The following is a description of a gene set: studied in species Homo sapiens We identified Pparg as a major orchestrator of the phenotype of adipose-tissue resident regulatory T cells (VAT Tregs). To establish the role of Pparg in shaping the VAT Tregs gene profile and cell dynamics, Tregs from lymph nodes and visceral adipose tissue of mice sufficient and deficient of Pparg expression in Tregs were double sorted for microarray analysis. Genes down-regulated in T conv from lymph node of elderly (retired breeder) mice: wildtype versus PPARG knockout. Human Gene Set: GSE37532_WT_VS_PPARG_KO_LN_TCONV_DN from publication Cipolletta D, Feuerer M, Li A, Kamei N, Lee J, Shoelson SE, Benoist C, Mathis D (PMID 22722857), and this is the list of marker genes: SNX9, CLIC1, DPYSL2, H1-5 (H1.5 linker histone, cluster member), NUDT4, BUB1B, SLC25A24, ZNG1A, CCNA2, LGALS1, UGDH, CALM1, S100A10, NSD2, ANTKMT, COPS9, NCAPG, HELLS, IFI30, C15orf40, PRR13, XCL1, CDKN2AIPNL, PCNA, REEP5, CDCA3, PRF1, GMCL1, LIME1, PDIA6, MICOS10, PRC1, SMC2, CENPL, IFNG (interferon gamma), PLSCR1, TNFRSF1A, CDC14A, TPM4, ATP5PB, ADPRH, TRAPPC1, ITGAL, PPAT, CCL3, CAPG, CRIP1, CLDND2, ITGB1 (integrin subunit beta 1), PIK3AP1, METAP2, ETFB, EFHD2, NEK7, FAM185A, SHCBP1, TAP2, PTMS, PSMB9, NRP1, NUF2, SCAMP2, ITGAV, VAV3, LGALS3, CENPE (centromere protein E), SAV1, HPF1, THEMIS2, SWAP70, TBCB, S1PR5, RNASE1, PEPD, UBA3, NCOA7, KNOP1, ANXA2, ATP6V0C, AP3B1, FKBP2, SH3BGRL3, PPP1R8, SNX25, SELENOS, H2AC15, LPIN1, MSRB1, CDC34, PTMA, GNG10, CDCA2, LIPA, CD38, PSMD5, SEMA4D, N4BP1, RNF10, AZIN1, CTSD, DOCK5, CWC15, PLEK, PPT1, SERPINB9, GEN1, HNRNPA2B1, MANF, ARSB, HLA-B, GSAP, GLRX, MKI67, ADAM8, CATSPERB, HMMR, TRPV2, RBBP8, SMPDL3B, MAST2, AIMP2, NOD1, BHLHE40, BIRC5, NMT1, TIGIT, TICRR, GZMA, H2AZ1, KNL1, MYADM, ASNSD1, DEK, YWHAH, DAZAP2, C11orf54, RTN4IP1, ASF1B, CDC25B, HMGB2, NAXE, CASP1, ANAPC15, ITGAX, STT3A, SYTL2 (NCBI Gene Id 84564), TACC3, COX7B, MYO18A, RORA, COX17, KIF11, ZDHHC2, EDF1, H2BC4, VIM, CLIC4, HEG1, VWA8, PTPN7, CSF1, EEA1, RNF170, CCL5, S100A6, NCAPG2, MYG1, ID2, SYAP1, CRYBA2, CAP1, GPR65 (NCBI Gene Id 8477), CCDC50 (NCBI Gene Id 338335), ENTPD1, ACTG1, ANP32E, RMND5A, PHF11, CHEK1, RAD51, CCR2, GTSE1, ATF1, PANK3, CALM2